The following is a description of a gene set: The directed movement of large protein complexes along microtubules from the tip of a cilium (also called flagellum) toward the cell body, mediated by motor proteins. Human Gene Set: GOBP_INTRACILIARY_RETROGRADE_TRANSPORT studied in species Homo sapiens, and this is the list of marker genes: DYNC2I1, TTC21B (tetratricopeptide repeat domain 21B), IFT140, DYNC2LI1, DYNC2I2, TTC21A, IFT43, CILK1, WDR19, WDR35, DYNC2H1, DYNLL1, IFT122, DYNLT2B